Given this list of marker genes Cxcl5 (NCBI Gene Id 29874), Hrg, Elane, Apol11a, Gpx1, Gapdh-ps15 (glyceraldehyde-3-phosphate dehydrogenase, pseudogene 15), Pomc, Ncf1, Romo1, Tusc2, Dao, Mbl2, Gapdhrt2, Camp, Hspd1, Fn1, Trem1, Gapdh, Nlrp6, Gapdhrt, Mbl1, Myd88, Plg, Spag11b, Scnn1b, Gpx2, Ctsg, Arg1, Ltf, Defa20, Pcyox1l (prenylcysteine oxidase 1 like), Cxcl1, F2, F2rl1, Ddb1, Trem3, Cysrt1, here is a description of the gene set: Mouse Gene Set: GOBP_BIOLOGICAL_PROCESS_INVOLVED_IN_INTERACTION_WITH_SYMBIONT studied in species Mus musculus An interaction between two organisms living together in more or less intimate association. The term symbiont is used for the smaller (macro) of the two members of a symbiosis; the various forms of symbiosis include parasitism, commensalism and mutualism.